Given this list of marker genes Gabarap, Nod2, Ube2n, Ripk2, Skp2, Birc3, Nmi, Birc2, Xiap, Marchf7, Ube2v2, Fbxo4, Hamp2, Ptpn22, Spsb4, Hamp, Ddx3x, D1Pas1, Rnf40, Ube2d1, Ube2v1, Prkn, here is a description of the gene set: Mouse Gene Set: GOBP_POSITIVE_REGULATION_OF_PROTEIN_POLYUBIQUITINATION studied in species Mus musculus Any process that activates or increases the frequency, rate or extent of protein polyubiquitination.